The following is a description of a gene set: Binding to a protein involved in the process of removing sections of the primary RNA transcript to form the mature form of the RNA. studied in species Mus musculus Mouse Gene Set: GOMF_SPLICING_FACTOR_BINDING, and this is the list of marker genes: Uhmk1, Rbm14, Rbm20, Sf3b5, Sf3b1, Sf3b4